The following is a description of a gene set: part of: Defective factor VIII causes hemophilia A Reactome Pathway: Defective F8 sulfation at Y1699 species: Homo sapiens Hemophilia A (HA) is a bleeding disorder caused by lack of or a defective factor VIII (FVIII) protein and results from defects in the F8 gene (Peyvandi F et al. 2016).<p>In healthy individuals, FVIII is synthesized as a large glycoprotein of 2351 amino acids with a discrete domain structure: A1-A2-B-A3-C1-C2 (Wood WI et al. 1984; Vehar GA et al. 1984; Toole JJ et al. 1984). Upon synthesis, FVIII is translocated into the lumen of the endoplasmic reticulum (ER), where it undergoes extensive processing including cleavage of a signal peptide and N-linked glycosylation at asparagine residues (Kaufman RJ et al. 1988, 1997; Kaufman RJ 1998). In the ER lumen of mammalian cells FVIII interacts with the protein chaperones calnexin (CNX), calreticulin (CRT), and immunoglobulin-binding protein (BiP or GRP78) that facilitate proper folding of proteins prior to trafficking to the Golgi compartment (Marquette KA et al. 1995; Swaroop M et al. 1997; Pipe SW et al. 1998; Kaufman RJ et al. 1997; Kaufman RJ 1998). Trafficking from the ER to the Golgi compartment is facilitated by LMAN1 and multiple combined factor deficiency 2 (MCFD2) cargo receptor complex (Zhang B et al. 2005; Zheng, C et al. 2010, 2013). Within the Golgi apparatus, FVIII is subject to further processing, including modification of the N-linked oligosaccharides to complex-type structures, O-linked glycosylation, and sulfation of specific Tyr-residues (Kaufman RJ 1998). Upon secretion from the cell, FVIII is cleaved at two sites in the B-domain to form a heterodimer consisting of the heavy chain containing the A1-A2-B domains in a metal ion-dependent complex with the light chain consisting of the A3-C1-C2 domains (Kaufman RJ et al. The module includes also an event of defective post-translational tyrosine sulfonation of FVIII in the Golgi apparatus that is required for the optimal interaction between the secreted FVIII and the von Willebrand factor (VWF)., and this is the list of marker genes: F8, TPST2, TPST1